Given this list of marker genes CHP1, MTOR, HOMER3, TBC1D10C, ACTN3, MYOZ1, GSK3B, HOMER2, ATP2B4, DYRK2, MAPK7, RCAN1 (regulator of calcineurin 1), PRNP (prion protein (Kanno blood group)), MYOZ2, FHL2, here is a description of the gene set: species: Homo sapiens Any process that stops, prevents or reduces the frequency, rate or extent of calcineurin-mediated signaling. Human Gene Set: GOBP_NEGATIVE_REGULATION_OF_CALCINEURIN_MEDIATED_SIGNALING